Given this list of marker genes Bcl2l1, Lrrk2, Cxadr, Prkn, Pip5k1c, Slc17a7, Stx1b, Nlgn1, Kcnc3, Rock1, Sh3gl1, Snx9, Dnm3, Ophn1, Actb, Scamp5, Mff, Ap2m1, Ppp3cb, Syt7, Abca13 (NCBI Gene Id 435246), Picalm, Actg1, Vamp2, Gripap1, Tor1a, Synj1, Vamp4, Fgf14, Rac1, Dgkq, Syt11, Arpc3, Dnm1, Btbd9, Dnm1l, Pclo, Ppp3cc, Cyfip1, Park7, Plaa, Snap91, here is a description of the gene set: Any process that modulates the frequency, rate or extent of synaptic vesicle recycling. Mouse Gene Set: GOBP_REGULATION_OF_SYNAPTIC_VESICLE_RECYCLING studied in species Mus musculus